The following is a description of a gene set: Human Gene Set: KIM_MYC_AMPLIFICATION_TARGETS_DN from publication Kim YH, Girard L, Giacomini CP, Wang P, Hernandez-Boussard T, Tibshirani R, Minna JD, Pollack JR (PMID 16116477) DNA amplifications and deletions frequently contribute to the development and progression of lung cancer. To identify such novel alterations in small cell lung cancer (SCLC), we performed comparative genomic hybridization on a set of 24 SCLC cell lines, using cDNA microarrays representing approximately 22,000 human genes (providing an average mapping resolution of <70 kb). We identified localized DNA amplifications corresponding to oncogenes known to be amplified in SCLC, including MYC (8q24), MYCN (2p24) and MYCL1 (1p34). Additional highly localized DNA amplifications suggested candidate oncogenes not previously identified as amplified in SCLC, including the antiapoptotic genes TNFRSF4 (1p36), DAD1 (14q11), BCL2L1 (20q11) and BCL2L2 (14q11). Likewise, newly discovered PCR-validated homozygous deletions suggested candidate tumor-suppressor genes, including the proapoptotic genes MAPK10 (4q21) and TNFRSF6 (10q23). To characterize the effect of DNA amplification on gene expression patterns, we performed expression profiling using the same microarray platform. Among our findings, we identified sets of genes whose expression correlated with MYC, MYCN or MYCL1 amplification, with surprisingly little overlap among gene sets. While both MYC and MYCN amplification were associated with increased and decreased expression of known MYC upregulated and downregulated targets, respectively, MYCL1 amplification was associated only with the latter. Our findings support a role of altered apoptotic balance in the pathogenesis of SCLC, and suggest that MYC family genes might affect oncogenesis through distinct sets of targets, in particular implicating the importance of transcriptional repression. Genes negatively correlated with amplifications of MYC in SCLC (small cell lung cancer) cell lines. studied in species Homo sapiens, and this is the list of marker genes: HS2ST1, ZNF93, TBPL1, TTC39B, PAXIP1, PLEKHA2, ATP2B4, BRD10, HECTD4 (NCBI Gene Id 283450), SORBS2, XRRA1, KIRREL3, CCDC171, HMG20B, CEBPD, PIF1 (PIF1 5'-to-3' DNA helicase), PRUNE2, ZNF43, ZNF880 (NCBI Gene Id 400713), COA6, SPAG1, TCF19, ELOVL7, GRP, F11R, CCDC191, SCNN1A, PLEKHG1, MYO6, RASSF6, ATL3, IFIH1, LPP, NUCB2, ZNF468, GCA, LCA5, DNER, LAMP1, GAB2, FAM111A, GAS2L3, BCL2 (NCBI Gene Id 596), CNTLN (NCBI Gene Id 54875), RIMKLB, ATCAY, DCLK1, EXO5, CCDC146, RMST, ZNF292, SPAG6, HEATR1, TMEM67, OPTN (optineurin), DPYSL3, KIF13B, MARVELD2, IL17RD, PATJ, CLEC2D, ADAMTS18, LGALS8, GRHL2, CFB, RNF19A, CDH1, PTPRN2, IL17RB, ETV6, RIGI, KLF5, ZMAT4, CYRIA, CAPN1, NFATC2, RORA, NEBL, RAB3B, KITLG, ZNF83, CTNNA1, CFLAR, ILDR2, ERO1B, ELF3, PPCS (NCBI Gene Id 79717), ZNF347, ZNF818P, KCNMB2, ZNF415, PLXNA2, TMBIM4, SHROOM3, FNBP1L, NKX2-1, ZSWIM6, RNF38